Given this list of marker genes Adcy8, Fmr1 (NCBI Gene Id 207836), Grid2, Cbln1 (NCBI Gene Id 12404), Ppp1r9a, Kcnb1, Iqsec2, Mapt, Stau2, Pirb, here is a description of the gene set: studied in species Mus musculus Any process that activates or increases the frequency, rate or extent of long term synaptic depression. Mouse Gene Set: GOBP_POSITIVE_REGULATION_OF_LONG_TERM_SYNAPTIC_DEPRESSION